Given this list of marker genes H2-Ea, Tgfb1 (transforming growth factor, beta 1), Gimap3, Ifng, Gimap5, Kcnk18, Klhl25 (NCBI Gene Id 76553), Il2rg, Foxp3, here is a description of the gene set: Mouse Gene Set: GOBP_REGULATION_OF_CD4_POSITIVE_CD25_POSITIVE_ALPHA_BETA_REGULATORY_T_CELL_DIFFERENTIATION Any process that modulates the frequency, rate or extent of differentiation of CD4-positive, CD25-positive, alpha-beta regulatory T cells. species: Mus musculus